Given this list of marker genes Nudt18, Spmip6, Rasd2, Trim66, Dennd1a, Sele, Pmpca, Slc1a4, Ccdc60, P4ha1, Mms19, Ppp2r5e, Wnt3a, Faf2, Trim37, St8sia2, Rnf182, Mfap3, Jmy (NCBI Gene Id 57748), Apbb2, Smim14, Stk25, Aldh6a1, Itga1, Trim45, Rab12, Thnsl1, Sdf4, Igsf6, Hykk, Gnaq, Gpm6a, Pomgnt1, Tafa5, Tomm22, Serpinb7, Nars1, Trpc5, Hoxc10, Avpr2, Poldip3, Haus8 (4HAUS augmin-like complex, subunit 8), Dnajc18, Srpx, Rab7b, Zfp410, Sertad4, Sertm1, Tcerg1l, Glce (glucuronyl C5-epimerase), here is a description of the gene set: from publication Chen Y, Wang X (PMID 31504780) Mouse Gene Set: MIR_12198_3P species: Mus musculus Genes predicted to be targets of miRBase v22 microRNA mmu_miR_12198_3p in miRDB v6.0 with MirTarget v4 prediction scores > 80 (high confidence targets).